The following is a description of a gene set: from publication Yevshin I, Sharipov R, Kolmykov S, Kondrakhin Y, Kolpakov F (PMID 30445619) species: Homo sapiens Human Gene Set: ZNF524_TARGET_GENES Genes containing one or more binding sites for (ZNF524) in their promoter regions (TSS -1000,+100 bp) as identified by GTRD version 20.06 ChIP-seq harmonization., and this is the list of marker genes: TPI1 (NCBI Gene Id 7167), SPPL3, RTEL1, IFNLR1, ZKSCAN3, KLLN, MYLIP, JPT1, FAM86FP, CEP57L1, ING5, METTL26, ASAH1-AS1, RFC1, NOP16, GBA1, EGR2, EPHA2, NLRX1, GTF3C5, CZIB-DT, PDE6D, PGBD2, NBR1 (NBR1 autophagy cargo receptor), NPM1, PIH1D2, SMG7, ODAD2, WDR76, GAPDH-DT, ENSA, COPS7B, NEMF, AJUBA, TMEM87A, MYO3A, SNAP47, ZKSCAN2, UBB, NCAM1, LLGL2, FCHSD2, HMG20A, MRPS2 (mitochondrial ribosomal protein S2), SLC16A1, BET1L, CENPU, NDUFA10, HEXIM1, MPHOSPH9, ARMH3, GABPB1-AS1, HDDC3, VPS9D1, SALL2, MICU3, SLCO5A1-AS1, RPL11, TMEM68, KDM1A, INTS13, MAP3K10, SGMS1-AS1, PEAK1, GARIN5A, MMAB, LRRC59, TMEM101, MED26, AGO3, CDON, FBXW8, MRM3 (NCBI Gene Id 55178), NSFL1C, KCTD5, MRPL44, BRMS1L, RTEL1-TNFRSF6B, C1orf220, PRKAA1, PPP2R5B, GAPDH, KLRG1, TSPAN9, TRIM26, SLC16A1-AS1, R3HCC1 (NCBI Gene Id 203069), MOB1A, DDX50, FGD5-AS1, SBK1 (SH3 domain binding kinase 1), FRMD4B, RNPS1, SARAF, LRP1, C6orf136, BMS1, CCDC6, NUTM2A-AS1, VPS33A, MTF2, MAML3, WDR11-DT, EMC10, CFAP20, PPEF1, LUC7L, KMT5B, B4GAT1-DT, PAWRP1, CCNG1, B4GAT1 (beta-1,4-glucuronyltransferase 1), WDR24, ENSG00000246465, MIR3677HG, TFAP2A, SLC41A2, ANKRD13A, ACKR2, ALG11, FANCC, NOC2L, MXD3, CD2AP-DT, ATP7B, IL23A, ZNF649 (zinc finger protein 649), DOCK7-DT, C17orf75, CZIB, NECTIN2, SCN1B, GLOD4, INO80, SMARCD2, NKAPD1, ELOVL7, VARS1, SLC27A5, QTRT1, OCEL1, CARS1, DMAP1, AKAP9, CELSR3, NOP56, TMEM248, NUCKS1, DUSP1, SSBP3 (single stranded DNA binding protein 3), ZCCHC4, NDUFC2-KCTD14, NSD1, SDF4, CD2AP, BRF2, SLC44A1, TGS1 (NCBI Gene Id 96764), ZDHHC1, P3H3, NELFA, ZNF276, CCNI, NICN1, MIB2, C5orf24, MED25, INTS12, MIR615, REL, CCDC124, PLK3, ARHGEF12, ITFG2, FOXL1, FUT10, RFX1, PNPLA3, PLCXD1, DRG2 (NCBI Gene Id 1819), ZNF382, STMN3 (NCBI Gene Id 50861), TMEM183A, C1orf159, NICOL1, DNM3, C11orf68 (NCBI Gene Id 83638), ZBTB40, GANC, BET1, PFKFB3, NBPF12, CACNB3, HAP1, PTOV1-AS1, ATP5MFP1, BRWD1, ACAT2, CFAP418, PPCDC, NMT2, JMJD4, MAP3K5, OCIAD1, RIC8A, NR2C2, ATXN2, HDAC2-AS2, ITGB3BP, SOX13 (SRY-box transcription factor 13), GABPB1, CSTPP1, GNAS, FOXJ3, B3GALT6, CCDC107, AURKAIP1, RERE, DOCK7, ZNF205, MMP25-AS1, UBTD1, PFKFB3-AS1, SRRM2 (serine/arginine repetitive matrix 2), ZNRF2, TTLL7, PTOV1, LINC01315, HDAC8, GSTCD, SLC4A2, RSPO3, HPS1, SESN1, PAN2, ATG2A, PDHB, ENSG00000247416, JPX (JPX transcript, XIST activator), STX16-NPEPL1, ZNF594, SLC25A6, MTG1, PBLD, DUS1L, BRCA1, TOP3B, EFNB3, ZNF3, ASAH1, VPS37C, TSHZ2, ZNF213-AS1, ZSCAN12, ARID1A (AT-rich interaction domain 1A), TNPO1, EXOC7, RSL24D1, MIRLET7BHG, NDUFS7, PLEKHG2, MIR3912, XKR6, NREP, PIK3R3, DPYSL5 (NCBI Gene Id 56896), WDR11, CDC42SE1, SAMD8, ESRP2, UCHL1, SF3A3, MARCHF4, FRS3, TM9SF4, FAM200A, PLCD3, RNF31, CUEDC2, PIERCE1, REL-DT, ITFG2-AS1, FGFR1OP2, GABPB2, DIAPH1, RNU1-6P, LSM2, CTNNB1, ZCCHC24, SGMS1, AJUBA-DT, C1orf35, PLEKHA8, SEC13, MRPL4, STX16, RPL29, POLR3E, MARCHF8, EXD3, EFCAB7, ZNF594-DT, ZNF34, NUBP1, MAX, PLA2G15, SRRM2-AS1, LRFN4, HCFC1, MTERF4, DDX55, HDAC2, FRA10AC1, MYO1C, HOXA4, MIR1302-3, SLC33A1, REXO4, PTEN, FBRSL1, NDUFC2, SMG7-AS1, MVK, PLEC, KMT2E, TLE3, PSME2, PCDH9, AGAP2-AS1, UCHL1-DT, MRPL39, ZNF829, KAT6B, PDE8A, NDST2, EIF2D, HACD3, HELB, NOXA1, NR2F6, ZNF593, NDUFC1, MCRIP2, USP30, NUS1, TMEM187, SLCO5A1, DRAP1, NKIRAS2, XKR8, MTRFR, SLC39A3, M6PR (NCBI Gene Id 4074), GNB2 (NCBI Gene Id 96628)